The following is a description of a gene set: Mouse Gene Set: GOBP_RIBONUCLEOPROTEIN_COMPLEX_BIOGENESIS species: Mus musculus A cellular process that results in the biosynthesis of constituent macromolecules, assembly, and arrangement of constituent parts of a complex containing RNA and proteins. Includes the biosynthesis of the constituent RNA and protein molecules, and those macromolecular modifications that are involved in synthesis or assembly of the ribonucleoprotein complex., and this is the list of marker genes: Wdr43, Luc7l3, Snrpd1, Nol7, Srfbp1, Utp14b, Adar, Abcf1, mt-Rnr1, Tma16, Ddx39b, U2af2, Fcf1, Nhp2, Rps25, Urb2, Zfp622, Tbl3, Rrp1, Rps15, Gtpbp4, Shq1, Ptbp2, Ddx21, Gemin7, Hsp90aa1, Ngdn, Exosc8, Snrpg, Prmt5, mt-Rnr2, Strap, Rasl2-9, Glul, Rps27, Sf3a1, Nom1, Rpf2, Rplp0, Srpk2, Eral1, Utp3, Prpf3, Ipo4, Ddx10, Dnttip2, Lsm2, Prpf4b, Nsun3, Exosc7, Ddx18, Urb1, Ckap5, Mcat, Luc7l, Eif3d, Exosc4, Utp14a, Tarbp2, Wdr74, Ago4, Srsf10, Mbnl1, Prpf6, Rps4x, Rsl24d1, Rpl7a, Mpv17l, Mrpl10, Rps14 (ribosomal protein S14), Prpf8, Pes1, Gemin8, Rpusd2, Nsa2, Psip1, Eif3j2, Utp20, Celf5, Gnl2, Bud23, Celf2, Pin4, Eif3i, Gemin6-ps, Smn1, Fbll1, Rpp38, C1d, Rps5, Scaf11, Dcaf13, Bysl, Pih1d1, Utp15, Ruvbl1, Ppan, Pno1, Ybey, Exosc3, Htatsf1, Prpf39, Mdn1, Dkc1 (NCBI Gene Id 56842), Nop56, Ptges3-ps, Snu13, Pih1d2, Rbm34, Chd7, Snrpf, Eif2s3x, Ltv1, D1Pas1, Npm3 (nucleoplasmin 3), Rps7, Rps28, Sf3a3, Rpl7l1, Wdr46, Wdr12, Nmd3, Prpf19, Eif3j1, Utp23, Ddx27 (DEAD box helicase 27), Snrpert, Zfp735, Clns1a, Rpl11, Rps21, Malsu1, Celf1, Npm1, Fbl, Rps23, Slu7, Dicer1, Rpl5, Yju2, Pten, Rbm10, Tsr3, Ddx47, Rrp1b, Rrp7a, Rpl13a, Nip7, Las1l, Brix1, Airim, Rps12, Lyar (NCBI Gene Id 17089), Drosha, Ddx3x, Nop14 (NOP14 nucleolar protein), 2810004N23Rik, Noc2l, Usp36, Exosc10, Tssc4, Usp4, Eif4b, Eif3a, Gnl3l, Crnkl1, Sfswap, Gtf2h5 (NCBI Gene Id 72566), Snrpd2, Nopchap1, Snrpb, Rps8, Nvl, Rrp15, Zfp658, Rpsa, Celf6, Exosc6, Ipo9, Rbis, Dhx9, Exosc5, Celf3, Exosc9, Wdr75, Rpl7, Nol8, Ak6, Rpf1, Rrp8, Sde2, Sf3a2, Nle1, Mpv17l2, Eif3h, Ddx52, Pop4, Snrnp200, Gtf3a, Atr, Eif3e, Mak16, Ddx56, Sdad1, Mtrex (NCBI Gene Id 72198), Ddx28, Pop5, Riok2, Gemin4, Rps19, Znhit6, Esf1, Celf4, Eif2s2, Rps9, Eif3g, Wdr55 (WD repeat domain 55), Ddx31, Tsc1, Setx (senataxin), Ftsj3 (FtsJ RNA 2'-O-methyltransferase 3), Pdcd11, Nudt16, 1700009N14Rik, Srpk1, Mterf3, Nol10, Mrm1, Eif2s3y, Prpf18, Mterf4, Mrm2, Nop53, Prpf31, Ddx54, Mettl15, Rcc1l, Eif6, Riok1, Ddx46, Utp18 (UTP18 small subunit processome component), Coil, Rpusd4, Aatf, Lsg1, Trmt2b, Ncl (nucleolin), Sf3b1, Eif3k (NCBI Gene Id 73830), Isg20, Luc7l2, Bms1, Eif5b, Wdr36, Emg1, Chaer1, Dimt1, Ngrn, Rrn3, Snrpd3, Afg2b, Isy1, Mettl18, Rrp9, Nsun5, Abt1, Eif2a, Atm, Pak1ip1, C1qbp, Kat2b, Aar2, Mrto4, Prmt7, Rps6-ps4 (ribosomal protein S6, pseudogene 4), Snrpc (NCBI Gene Id 20630), Eif3l, Ago2 (argonaute RISC catalytic subunit 2), Ncbp1, Rps6, Tsr2, Eif5, Zfp616, Tdrd6, Nop16, Eif3f, Ruvbl2, Riok3, Ddx42, Tfb2m, Ddx17, Prkdc, Noc4l, Imp3, Nob1, Fdxacb1, Rpp25, Dhx37, Utp25 (UTP25 small subunit processome component), Usp16, Rpl35a, Ebna1bp2, Heatr1, Mcts2, LTO1, Frg1, Rps27l, Nat10, Dhx29, Eif1ax, Rps15a, Krr1, Rbm5, Isg20l2, Rexo1, Rps3a1 (NCBI Gene Id 20091), Pop7, Rpl26, Sirt7, Lsm6, Tfb1m, Pa2g4, Dhx30, Gcfc2, Cdkn2a, Rsrp1, Eif4a3, Afg2a, Rbfa, Nop2, Eif3m, Trmt112, Nup88, Ythdf2, Sart3, Nop9, Riox2, Mybbp1a, Greb1l, Rps19bp1, Gemin2, Xpo1, Heatr3, Tsr1, Myg1, Nsun4, Gemin5, Zrsr2, Rps24, Rexo5, Mrps2, Rcl1, Exosc2 (exosome component 2), Exosc1, Cinp, Sbds, Utp6 (NCBI Gene Id 216987), Xrcc5, Mphosph10, Rps16, Rpl14 (ribosomal protein L14), Ddx49, Srsf12, Rrp36, Surf6, Fau, Srsf6, Ran, Nufip1, Eif1a, Ddx20, Mettl17, Mrps7, Srsf1, Nol6, Hsp90ab1, Ago3, Denr, Rps17, Pelp1, Nop10, Wdr18, Riox1, Rpp30, Rexo4 (NCBI Gene Id 277501), Ago1, Nol3 (nucleolar protein 3 (apoptosis repressor with CARD domain)), Fastkd2, Cul4a, Rps27a, Rrs1, Zfp593, Gemin6, Kri1, Eif3b, Pwp1, Rbmx, Rpl10l, Bop1 (block of proliferation 1), Suv39h1, Lsm4, Ddx51, Tent4b, Prkra, Imp4, Rpl24, Wdr77, Khdc4, Cul4b, Xab2, Rpl27, Eif3c, Slx9, Eri1, Sart1, Nol9, Efl1, Gar1, Srpk3, Ercc2, Eif2d (eukaryotic translation initiation factor 2D), Clp1, Rpl35, Wdr3, Gtpbp10, Ptges3, Rpl38, Znhit3, Usp39, Mcts1 (malignant T cell amplified sequence 1), Pwp2 (PWP2 periodic tryptophan protein homolog (yeast)), Snrpe, Utp11, Grwd1, Naf1, Nop58, Rps13, Nol11, Taf9, Mettl16, Dis3, Rps27rt, Wbp11, Utp4, Zcchc4, Rps11, Mettl5, Mphosph6, Rpusd1, Ythdc1, Puf60, Eif4h, Noa1 (NCBI Gene Id 67056), Rnasel, Rpp40, Mrm3